The following is a description of a gene set: electronically inferred by orthology from the curated human pathway This event has been computationally inferred from an event that has been demonstrated in another species.<p>The inference is based on the homology mapping from PANTHER. Briefly, reactions for which all involved PhysicalEntities (in input, output and catalyst) have a mapped orthologue/paralogue (for complexes at least 75% of components must have a mapping) are inferred to the other species. species: Mus musculus Reactome Pathway: Serotonin clearance from the synaptic cleft part of: Neurotransmitter clearance, and this is the list of marker genes: Aldh2